Given this list of marker genes HSH2D, CXCR6, NUPR1, RNF114 (ring finger protein 114), TMEM229A, HOPX, IL18RAP, SERPINB9, STAT2, CISH, SV2C, AKNAD1, ERAP1, NUFIP1, TREML2, ICOS, TAPBP, CCR8, TMEM163, SLC43A3 (solute carrier family 43 member 3), NR4A2, IFIT2, NRG1, H1-1, GEM (GTP binding protein overexpressed in skeletal muscle), SLPI, ZAP70, PLA2G4C, CD27, INSRR, RAB19, PAX7, EPSTI1, CD8A, NMI, GRAP2, PARP3, RUNX2, GSTT1, LEF1, AIDA, PSME1 (proteasome activator subunit 1), MFSD2A, PARP12, PRPH, SLC14A1, TRAFD1, RNF19B, UTF1, PTTG1, TAGAP, DGKA, IFI35, DBNL, CREM, IL36G, GBP6, NLRC5 (NLR family CARD domain containing 5), BST2, SAMSN1, ALB, RUNX3, IFITM1, CXCL10, TMBIM4, CIMIP2B, CIITA, PARP11, IL12RB1, KLRC1, TNFRSF18, PROCR, NFKBIE, NAMPT, SLC31A2, LAP3, PDCD1LG2, REL (NCBI Gene Id 5966), EIF4E3, DHX58, LPAR1, NOD1, CASP7, IFIT1, TSPO, RNF135 (NCBI Gene Id 84282), JAML, RGS16, SNX10, SYTL3, CRABP2, CCL5, CXCL11, PARP14, IFI44, ATF7IP2, CD69, GPR171, IL3, HERC5, IL18R1, THEMIS, LCN2, ARHGAP15, FILIP1L, GSDMD, ITK, IL18BP, IL2RA, IFNGR1, BIRC3, RSAD2, MRAS, CTSO, TBX21, VIL1, LCK, GIMAP4, FAM107B, SEPTIN1, CD28, CD2, UBE2L6, USP18, PLAT, IFIT3, ATOH1, ADORA2A, ABHD16A, B2M, SLC25A22, RYBP, RTP4, ALDH1A1, KATNA1, OGFR, PTPN6, BATF2, NT5C3A, STAT1, APOL6, PLAAT3, TNFSF10, KCNJ13, ISG20, HSPB1, CSF2, EDN1, UBASH3A, HAVCR2, LONRF1, CD300LF, CD47, GBP5, MROH2B, LAT, RMDN3, ICAM1, LTB (NCBI Gene Id 4050), CTNNA3, PTPN22, CD3D, F2RL2, KCNK5, SERPING1, UPP1, CACNG3, SCN4A, SOCS1, ZBTB32, here is a description of the gene set: Human Gene Set: GSE7218_IGM_VS_IGG_SIGNAL_THGOUGH_ANTIGEN_BCELL_DN Genes down-regulated in B lymphocytes treated by anti-HEL and expressing BCR fusions with: IgM versus IgMG. from publication Horikawa K, Martin SW, Pogue SL, Silver K, Peng K, Takatsu K, Goodnow CC (PMID 17420266) species: Homo sapiens IgG cytoplasmic tail interferes with the induction of antigen-response genes